The following is a description of a gene set: part of: Signaling by Interleukins This event has been computationally inferred from an event that has been demonstrated in another species.<p>The inference is based on the homology mapping from PANTHER. Briefly, reactions for which all involved PhysicalEntities (in input, output and catalyst) have a mapped orthologue/paralogue (for complexes at least 75% of components must have a mapping) are inferred to the other species. electronically inferred by orthology from the curated human pathway studied in species Mus musculus Reactome Pathway: Interleukin-7 signaling, and this is the list of marker genes: H3c8, Irs2, H3c13, H3c7, Stat5a, H3c11, H3c6, H3c10, Brwd1, Jak3, H3c3, H3c4, Irs1, H3c15, H3c2, Pik3r2, Smarca4, Il2rg, H3c1, Tslp, Stat5b